The following is a description of a gene set: species: Homo sapiens Genes down-regulated in comparison of plasmacytoid dendritic cells from LAIV influenza vaccinee at day 7 post-vaccination vesus those from TIV influenza vaccinee at day 7. Systems vaccinology has emerged as an interdisciplinary field that combines systems wide measurements and network and predictive modeling applied to vaccinology. Here we used the systems vaccinology approach to study the molecular mechanisms underlying th from publication Nakaya HI, Wrammert J, Lee EK, Racioppi L, Marie-Kunze S, Haining WN, Means AR, Kasturi SP, Khan N, Li GM, McCausland M, Kanchan V, Kokko KE, Li S, Elbein R, Mehta AK, Aderem A, Subbarao K, Ahmed R, Pulendran B (PMID 21743478) Human Gene Set: GSE29618_LAIV_VS_TIV_FLU_VACCINE_DAY7_PDC_DN, and this is the list of marker genes: FXR2, FOXL2, MC3R, SGCE, LRRTM4, NMT2, CDH2, CTSO, FOXB1, SLCO3A1, KIF25, TRMT2B, PCTP, AGR2, GABARAP, KLHL28, INHBB, BAIAP3, GART, MSMB, PFN1 (profilin 1), KCTD14, CCND1, NCKAP1, TM4SF1, H2BC12L, TUBA8, AVPR1A, IKZF1 (IKAROS family zinc finger 1), FOXO3, SCARB1, NPY2R, B3GNT3, HIGD2A, TNIP3, HES2, CDC27, MRPL28, F10, TNFAIP1, SH3BGRL3, AKAP8L, SNAPC1, RAPGEF4, LEF1, HSPA2, KCNA2, H2BC21, PRKCSH, CPT2, AKAP6, SDC1, CCL8, PTPA, NKX2-2, TRIB2, HK1, RSAD2, EIF4G1, FSHB, ALX3, UGT8, FBRS, CTNND1, LIN7B, PCCB, ANP32A, QPCT, FLNA, ADCY1, CHPF2, TMEFF1, FOLR2, PCDHA9, ERBB3, TNS4, CHST1, ZNF43, PHB2, IFT81, ATXN2L, PLEKHJ1, ERBB4, PHYHIP, HLA-F-AS1, KNOP1, INHBA, G6PC3, H2BC10, WNK1, RAD21, PFDN2, CNN1, ADCK2, CDY1, CD1A, HPCAL1, KRT38, PPP2R5E, DENND2A, TMX4, TMCC1, PFKM, PRDM5, HLX, CCDC181 (NCBI Gene Id 57821), C1orf54, PER3 (NCBI Gene Id 8863), SEC62, APOD, IP6K2, H2AC18, PRL, LYZL6, TGM5, PDZD2, THY1, EPN3, SIGLEC8, IPO7, STC2, TNK1, S100A2, IFI16, IL1RAPL1, RAD23A, MARK2, BRME1, DPM2, RECQL4, ZNF204P, SCGB2A2, GDI1, GSE1, CD24, SIRT4, GKN1, SLC16A5, SPIN1, TNPO2, SIGMAR1, PDZRN4, DSG1, GNAI2, SHMT2, WNT1, SART3, FLVCR2, CLPTM1, MEX3D, IER2, NXT1, BRINP1, SMAD5, HSD17B7, H2AC17, ASCL1, KIF2A, OGDH, POLR3D (RNA polymerase III subunit D), TREX2, H2BC5, ACTA1, H2BC9, IRF3, FGFR4, TLR5, TEX30, PRMT8, STX5 (syntaxin 5), TMEM230, PRTN3, ACTL7A, GNAT3, OR7E24, WDR33, CNGA3, IGFBP5, PTRH2, PKMYT1, CLTB, ADO, CXCL13, CBS, NECTIN3, HECW1, CALCA, ACP1, CCL16, MAP3K6, DNALI1, BCL6, H4C8, UCN, ELAVL1, CXCL14, FGFR1, H2BC6, H2AC16, CYP2D6